The following is a description of a gene set: part of: Plasma lipoprotein clearance species: Homo sapiens Reactome Pathway: VLDL clearance Very-low-density lipoprotein (VLDL) is a lipoprotein made by the liver and mediates the export of triglycerides from the liver to the rest of the body. VLDL particles are bound by cell surface receptors and internalized in reactions annotated here., and this is the list of marker genes: VLDLR, APOC1, APOBR, LSR, APOC4, APOB